The following is a description of a gene set: species: Mus musculus Mouse Gene Set: CUI_MACROPHAGE_IL36A_RESPONSE_UP Genes positively differentially expressed in cell type: Macrophage upon treatment with cytokine: IL-36α in mouse lymph nodes in vivo. from publication Cui A, Huang T, Li S, Ma A, Pérez JL, Sander C, Keskin DB, Wu CJ, Fraenkel E, Hacohen N (PMID 38057668) Cytokines mediate cell-cell communication in the immune system and represent important therapeutic targets. A myriad of studies have highlighted their central role in immune function, yet we lack a global view of the cellular responses of each immune cell type to each cytokine. To address this gap, the authors created the Immune Dictionary, a compendium of single-cell transcriptomic profiles of more than 17 immune cell types in response to each of 86 cytokines (>1,400 cytokine-cell type combinations) in mouse lymph nodes in vivo. A cytokine-centric view of the dictionary revealed that most cytokines induce highly cell-type-specific responses. For example, the inflammatory cytokine interleukin-1β induces distinct gene programmes in almost every cell type. A cell-type-centric view of the dictionary identified more than 66 cytokine-driven cellular polarization states across immune cell types, including previously uncharacterized states such as an interleukin-18-induced polyfunctional natural killer cell state., and this is the list of marker genes: Nhp2, Cebpd, Mybbp1a, Psmd11, Ssh2, Basp1, Ranbp1, Rars1 (NCBI Gene Id 76827), Eif4g2, Rrp12, Ccdc86, Ppa1, Nolc1, Msr1, Tfec, Arpc4, Pdcd1lg2, Mt2, Tpm4, Nifk, Glipr2, Lilrb4b, Pfn1, Adsl, Tomm20, Slc15a3, Chchd4, S100a8, Eif4ebp1, Hbegf, Hmox1, Psma3, Macir, Ran, Slfn2, Agfg1, Hs3st3b1, Ddx21 (NCBI Gene Id 56200), Ccl9, Eif6, Riok3, Gtpbp4, BC005537, Ccl6, Eif2s2, Tuba1c (tubulin, alpha 1C), Ccl12, Wfdc17, Impdh2, Cxcl9, Txnrd1, Rbms1, Ptpn1, Tma16, Set, H3f3b, Nop56, Snu13, Ifi47, Hnrnpab, Dcun1d5, Xbp1, Plaur, Pnp, Bcl2a1d, Ctu2, Prpf31, Tor1aip2, Stk40, Gar1, Ywhag, Cfl1, Sar1a, Dkc1, Litaf, Csrp1, Pa2g4, Tubb6, Etv6, Eef1e1, Eif4a1, Ccl2, Hnrnpf, Nol8, U2af1, Eif1a, Tpm3, Gnb4, Rsl24d1, Plek, Cycs, Dab2, Clic4, Atad3a, Iigp1, Osgin1, Gsap, Gch1, Ms4a6d, Ifi205, Glrx, Cxcl10, Ifi204, Saa3, Dok2, Clec4n, Scimp, Actg1, Odc1, Ybx3, Ifi211, Il1b, Srm, Actr3, Eif5a, Nsun2, Cd209e, Sod2, Ranbp2, Mt1, Sdc4, Cd274, Irgm1, Atp6v1b2, Etf1 (eukaryotic translation termination factor 1), Fth1, Cd300lf, Ncl, Bcl2a1b, Gbp5, Hspa8, Procr, Grwd1, Ccl7, Srgn, Timm8a1, Nop58, Serpina3g, Il1rn, Igtp, Snrpd1, Elavl1 (ELAV like RNA binding protein 1), Cnbp